The following is a description of a gene set: Potential therapeutics for SARS Human Gene Set: REACTOME_POTENTIAL_THERAPEUTICS_FOR_SARS species: Homo sapiens, and this is the list of marker genes: AP2B1, JAK2, FXYD2, RBX1, IGKV1D-39, MBD3, IGKV1-16, MTA2, IGKV2-30, IGLV1-47, SYK, CHD3, IGKV2-28, FXYD1, CRBN, FXYD4, HMG20B, IGKV3-20, IFNGR2, PTGES3, IGKV1D-33, FXYD6, IGHV3-11, IGKV1D-12, BTK, AP2M1, HDAC1, ATP1B3, IGLV1-40, ATP1A4, GRB2, IGKV4-1, HDAC2, TLR7, IGHV3-30, RBBP7, CUL3, REST, AP2A2, FNTB, IGLV1-44, MTA3, ATP1A1, BLNK, NFE2L2, CD79A, STAT2, JAK1, IGLV3-19, TYK2, IL6R, ZBP1, SAP30L, IGLV6-57, IGLV2-11, IMPDH1, IGHV2-5, ARID4A, ITGB1, ATP1A3, SAP18, RCOR1, IGLC2 (NCBI Gene Id 3538), JAK3, NR3C1, ACE2, ATP1A2, KEAP1, IGHV3-48, VAV1, IGLV2-23, IGKV1-33, IGHV4-59, NCK1, ITGA4, IGLV1-51, SIGMAR1 (NCBI Gene Id 80768), IGKV2D-30, PLCG2, IGHM, IGHD, IGKV3-15, IGLV2-14, IFNGR1, IGKV1-5, IGKV2D-40, FXYD3, IGKV2D-28, SH3KBP1, HSP90AB1, IGLV3-21, IGHV1-46, ATP1B2, ARID4B, BRD4, IFNAR1, KDM1A, IGKV1-17, IGHV4-39, IGHV3-53, GATAD2B, IGLC3, IMPDH2, IGKV1-39, IGLV3-27, SOS1, ROCK2, SUDS3, IGLV3-25, BRMS1, FXYD7, IGHV3-33, IGHV3-7, RBBP4, IGLV3-1, FKBP1A, COMT, HSP90AA1, IGHV3-23, GATAD2A, PDCD1, MTA1, SAP30, CYSLTR1 (NCBI Gene Id 10800), S1PR1, FURIN, IGHV4-34, TLR9, IGKV3D-20, IL1R1, TBK1, AP2S1, CHD4, AP2A1, RIPK1, IGKV3-11, IGLV2-8 (immunoglobulin lambda variable 2-8), IGKV5-2, IGLV7-43, IFNAR2, ROCK1, IGKV1D-16, FKBP4, IGKV1-12, VEGFA, CD79B, ATP1B1, IGHV3-13, IGHV2-70, IGHV1-2, FNTA, TUBB (tubulin beta class I), IGHV1-69, PHF21A